The following is a description of a gene set: Mouse Gene Set: GOBP_HEART_FIELD_SPECIFICATION The process that results in the delineation of a specific region of the lateral mesoderm into the area in which the heart will develop. species: Mus musculus, and this is the list of marker genes: Lrp2, Bmp2, Robo2, Bmp4, Gata5, Wnt11, Axin2, Dkk1, Smarcd3 (SWI/SNF related, matrix associated, actin dependent regulator of chromatin, subfamily d, member 3), Mef2c, Ext1, Rbpj, Mesp1, Wnt5a, Robo1, Foxh1, Isl1